The following is a description of a gene set: Mouse Gene Set: GOBP_T_HELPER_2_CELL_DIFFERENTIATION studied in species Mus musculus The process in which a relatively unspecialized T cell acquires specialized features of a T-helper 2 (Th2) cell. A Th2 cell is a CD4-positive, alpha-beta T cell that has the phenotype GATA-3-positive and produces interleukin-4., and this is the list of marker genes: Batf, Il4ra, Il6, Gata3, Zfp35, Rara, Tnfsf4, Myb, Anxa1, Il18, Socs5, Bcl6, Men1, Prkcz, Ascl2, Hlx, Kmt2a, Irf1, Il4, Nlrp3, Bcl3